Given this list of marker genes Tomt, Slc6a3, here is a description of the gene set: Reactome Pathway: Dopamine clearance from the synaptic cleft part of: Neurotransmitter clearance studied in species Mus musculus This event has been computationally inferred from an event that has been demonstrated in another species.<p>The inference is based on the homology mapping from PANTHER. Briefly, reactions for which all involved PhysicalEntities (in input, output and catalyst) have a mapped orthologue/paralogue (for complexes at least 75% of components must have a mapping) are inferred to the other species. electronically inferred by orthology from the curated human pathway